Given this list of marker genes Pa2g4, Cysltr1, Txn1, Cct3, Srsf10, Ifi27l2a, Gbp2, Ppp1r14b, Gzmc, Adam8, Hspa8, Hdgf, Ddx54 (DEAD box helicase 54), Atp5f1e, Trim12c, Irf1, Psma7, Hmgn3, Snrpd1, Wdr43, Atp5mk, Xbp1, Serbp1, Batf, Rnf213, Prdx1, Pgk1, Rab5c, Nhp2, Ppp1r14c (protein phosphatase 1, regulatory inhibitor subunit 14C), Pxdc1 (NCBI Gene Id 66895), Dtymk, Psma4, Morf4l2, Timm8a1 (NCBI Gene Id 30058), Cct8, Tmsb10, Atp1a1, Tapbpl, Eif3b, Casp8, Ncl, Mydgf, Hsp90ab1, Isg15, Rasa2, Phb1, Lsm6, Surf4 (surfeit gene 4), Nop56, Tnfrsf9, Gzmb, Isg20, Psme2, Bcl2l1, Nsun2, Pfn1, Cct5 (NCBI Gene Id 12465), Atp2a2, Nme1, Trac, Thyn1, Ppa1, Nfkb1, Cct2, Atp5mc1, Snrpa, Ndufc1, Naga, Tomm40, Il2rg, Chchd1, Pdap1, Zbp1, Eif1ax, Tmbim6, Gspt1, Sdc4, Acot7, Igtp, Gbp7, Mrto4, Ube2m, Pkm (NCBI Gene Id 18746), Hnrnpab, Ifi47, Cyba, Cacybp, Zfp281, Eif2s1, Srgap3, Smox, Icam1, Spcs3, Eif4a1, St13, Rtp4, Pou2f2, Eif4e, Vars1, Ddx39a, Ube2i, Mrpl12, Ehd1, P4hb, Kcnq1ot1, Larp1, Mettl1, Pcbp1, Cdc37, Sec61g, Uqcc2, Psme1 (proteasome (prosome, macropain) activator subunit 1 (PA28 alpha)), Stat2, H2-T23, Hprt1, Jak2, Lta, Gadd45g, Cnbp, Tap1, Bzw1, Lars1, Bsg, Eif1, Edf1, Snrpa1, Pdcd1lg2, Serpina3g, Npm3, Dbnl, Hnrnpa3, Ywhae, Xaf1, Bzw2, Cops6, Cdc34, Phgdh, Ctu2, Nifk, Pdia6, Ebna1bp2, Ifi35, Ddx18, Ogfr, Set, Dnajc3, Gbp6, Pim2, Tcp1, Stat1, Cycs, Snrpf, Erh, Eif1a, Canx, Pomp, Actg1, Myd88, Gzma, Hnrnpd, Ascc3, Hsp90b1, Hspd1, Parp9, Snrpb, Ubxn4, Iars1, Phf5a, Pdia3, Dad1, Psmb9, Tnfrsf25, Isy1, Ldha, Bcl2a1d, Ndufb4, B2m, Irgm2, Sdf4, Gnl3, Ifi206, Lman2, Gnpnat1, Ndufa12, Nlrc5, Psmb8, Lgals3bp, Ssb, Pnpt1, Krtcap2, Herpud1, Gbp8, Tmed2, Eif6, Strap, Ddx21, Ms4a4c, Hspa5, Eif3c, Shmt2, Zfp593, Bax, Ciao2a (cytosolic iron-sulfur assembly component 2A), Atp5mc3, Rab8b, Sar1a, H2-Q4, Odc1, Rpn1, Vmp1, Psmb10, Ran, Mrpl15, Ndufa5, Dnajb11, Cox7b, Eef1g, U2af1, Naa20, Ybx1, Cd82, Mrpl17, Slfn8, Psmb4, Tsr1, Psmd12, Spcs2, Eif5a, Fam162a, Ly6a, Hnrnph2, Tmed5, Nfkb2, C1qbp, Ly6e, Snrnp200, G3bp1, Ranbp1, Exoc4, Uqcr10, Nars1, Irgm1, Mybbp1a, Fbl, Rbm8a (NCBI Gene Id 98227), Calr, St6galnac4, Bola2, Parp14, Gbp5, Mrps6, Ssr4, Oasl2, Ube2l3, Gar1, Sdf2l1, Irf7, Cxcl10, Mt1, Fubp1, Chmp4b, Psmg4, Hnrnpdl, Uqcrq, Magt1, Cysltr2, Il2rb, Snrpd3, Abcf1, Srm, Sdhaf1, Trim30a, Nop58, Npm1, Mdn1, Iigp1, Fkbp2, Hsp90aa1, Banf1, Psmd7, Ppid, Socs3, Nop16, Mrpl52, Ndufb2, Hdlbp, Scfd1, Psma2, Mrpl54, Oas3, Dkc1, Tuba1b, Ptp4a2 (protein tyrosine phosphatase 4a2), Clic4, Naa50, Nolc1 (nucleolar and coiled-body phosphoprotein 1), Eif2s2, Selenos, Psme3, Bcl3, Rnps1, Dtx3l, Ahr, Bst2 (NCBI Gene Id 97478), Ostc, Ctss (NCBI Gene Id 13040), Ybx3, Bcl2a1b, Ilrun, Furin, Tapbp, Ufd1, Nop10, Ptma, Gbp4, Hyou1, Tars1, Ddx39b, Dnajc2, Mif, H2-K1, Sec11c, Zeb2, Gbp9, Tubb4b, Manf, Impdh2, Rangap1, Stat3, Rrp9, Nmi, Mthfd2, Slc25a5, Pon2, Cdv3, Lsm3, Avpi1, Apex1, Ifit3, Ranbp2, here is a description of the gene set: Genes positively differentially expressed in cell type: γδ T cell upon treatment with cytokine: IL-36α in mouse lymph nodes in vivo. studied in species Mus musculus Mouse Gene Set: CUI_T_CELL_GD_IL36A_RESPONSE_UP Cytokines mediate cell-cell communication in the immune system and represent important therapeutic targets. A myriad of studies have highlighted their central role in immune function, yet we lack a global view of the cellular responses of each immune cell type to each cytokine. To address this gap, the authors created the Immune Dictionary, a compendium of single-cell transcriptomic profiles of more than 17 immune cell types in response to each of 86 cytokines (>1,400 cytokine-cell type combinations) in mouse lymph nodes in vivo. A cytokine-centric view of the dictionary revealed that most cytokines induce highly cell-type-specific responses. For example, the inflammatory cytokine interleukin-1β induces distinct gene programmes in almost every cell type. A cell-type-centric view of the dictionary identified more than 66 cytokine-driven cellular polarization states across immune cell types, including previously uncharacterized states such as an interleukin-18-induced polyfunctional natural killer cell state. from publication Cui A, Huang T, Li S, Ma A, Pérez JL, Sander C, Keskin DB, Wu CJ, Fraenkel E, Hacohen N (PMID 38057668)